Given this list of marker genes PTPN11, CDKN1A, STAT5B (signal transducer and activator of transcription 5B), GAB2, PIM1, FLT3, NOX4, GRB2, BCL2L1, STAT5A, here is a description of the gene set: STAT5 activation downstream of FLT3 ITD mutants species: Homo sapiens Human Gene Set: REACTOME_STAT5_ACTIVATION_DOWNSTREAM_OF_FLT3_ITD_MUTANTS